Given this list of marker genes LEMD2, MYPN, MYL2, SYNE1, TNNT2, GYG1, ALPK3, MYBPC3, CSRP3, GLA, BSCL2, MAP2K2, MTFMT, here is a description of the gene set: Ventricular septal hypertrophy Human Gene Set: HP_VENTRICULAR_SEPTAL_HYPERTROPHY The dividing wall between left and right sides of the heart, thickens and bulges into the left ventricle. species: Homo sapiens